Given this list of marker genes HACD1, HSD17B4, HTD2, CDYL, HACD3, HACD4, HACD2, ECHS1, EHHADH, here is a description of the gene set: species: Homo sapiens Human Gene Set: GOMF_3_HYDROXYACYL_COA_DEHYDRATASE_ACTIVITY Catalysis of the reaction: a 3-hydroxy-fatty acyl-CoA = a (2E)-enoyl-CoA + H2O.